The following is a description of a gene set: Human Gene Set: REACTOME_REELIN_SIGNALLING_PATHWAY Reelin signalling pathway studied in species Homo sapiens, and this is the list of marker genes: FYN, DAB1, RELN, SH3KBP1, VLDLR